Given this list of marker genes UBE2C, UBE2Q2, UBE2B, OTULIN, UBE2L3, UBE2K, UBE2Z, UBE2A, UBE2E3, UBE2T, CDC34, UCHL3, UBA52, UBE2E1, USP9X, USP7, RPS27A, UBA1, UBE2R2, UBB, UBE2W, UBA6, UBE2S, UBE2H, UBC, USP5, UBE2D2, UBE2G1, UBE2G2, UBE2D1, here is a description of the gene set: Synthesis of active ubiquitin: roles of E1 and E2 enzymes studied in species Homo sapiens Human Gene Set: REACTOME_SYNTHESIS_OF_ACTIVE_UBIQUITIN_ROLES_OF_E1_AND_E2_ENZYMES